Given this list of marker genes PCDH19, PRKCA, FGF13, NFKB1, STXBP1 (NCBI Gene Id 6812), MTOR, AKT1, TNF, SCN1A, RICTOR, MLST8, SCN2B, PRR5L, SCN2A, MAPKAP1, SCN3A, PIK3CA, SCN4B, SCN3B, KCNA2, SCN1B, CHD2, MAPK11, SNTA1, PRR5, HCN1, CAMK2A, CALM1, SCN8A, here is a description of the gene set: Human Gene Set: WP_DRAVET_SYNDROME Dravet syndrome studied in species Homo sapiens